The following is a description of a gene set: species: Homo sapiens Any process that modulates the frequency, rate or extent of any cellular process that depends upon or alters the microtubule cytoskeleton. Human Gene Set: GOBP_REGULATION_OF_MICROTUBULE_BASED_PROCESS, and this is the list of marker genes: APC, POC1A, CFAP43, CAMSAP3, NME7, MAP10, MAP6, EPPIN, BICD2, RBM14, TOGARAM1, SLC39A12, ODAD2, TPX2, CFAP206, BORCS5, MAPRE1, CAMSAP2, CFAP20, HAUS2, STMND1, AKAP9, CAMSAP1, CHMP6, ERBB2, ATXN7, FSD1, XRCC3, MID1, CDKN1B, DYNLT2B, STMN3, PHLDB1, HAUS3, GPSM2, MAPK15, RSPH4A, PKD1, ANKRD53, MAPT, DEFB1, CEP70, MAP6D1, SIRT1, SKA1, MCPH1, RAB6C, DRG1, CYLD, GAS2L1, PLK1, APC2, GSK3B, BBS2, PHLDB2, TAC1, POC1B, FNTB, MAP9 (NCBI Gene Id 79884), HAUS1, TMEM67, TPR, CLXN, IGBP1, PPP1R35, DCTN1, CENATAC, RNASE10, ATAT1, CYB5D1, CHMP1A, SENP6 (NCBI Gene Id 26054), FES, DNAAF1, CCDC65, CDK11B, FAM107A, CCDC39, TACC3, TTC21B, CLTC, RHOA, RPS3, CDK2AP2, HAUS7, CHMP3, WDR47, MAP1A, PPP2CA, NEFH, PGAM4, GEN1, BRCA1, MAP2, XPO1, BBS1, CDH5, SLAIN1, TEX101, PPP2CB, HDGFL3, CCSAP, MKKS, FKBP4, SASS6 (SAS-6 centriolar assembly protein), CHMP4A, DRC1, MARK2, RNF4, TACR3, CLIP1, CENPJ, RAC1, FBXW5, INPP5J, CEP131, CKAP2, NUP62, CLIP3, CHMP4C, TAC3, SEMG1, PDCD6IP, PLK4, BBOF1 (NCBI Gene Id 80127), FGF13, PSRC1, STMN1, SKA3, EML2, KLHL42, NAT10, MARK4, BICD1, ADAM7, HAUS4, ARHGEF7, HAUS8, KIF21A, IQCF1, PAK1, PRDM14, RCC1, TRAF3IP1, TACR2, CEP120, DIAPH3, VPS4B, GIT1, CHMP7, ROCK1, EFNA5, CDK5R1, PRKAA2, SNCA, HDAC6, ABL1, DIAPH1, CCNL2, SPEF1, BBS4, NAV3, CHORDC1, RUFY4, RUFY3, KIF18A, TRIM46, TRIM58, PAFAH1B1, ROCK2, CCNF, STMN4, TAC4, EPHA3, GNAI1, RIPOR2, DYNC1H1, ARHGEF2 (Rho/Rac guanine nucleotide exchange factor 2), CCR6, SKA2, EML3, STIL, RAE1, SPAST, BORA, MAP1S, ARL2, LAMP1, CAV3, TRPV4, CATSPER1, KAT2B (NCBI Gene Id 8850), CHMP5, CKAP5, CCNL1, CHMP2B, DYRK1A, CHMP4B (NCBI Gene Id 60501), CDK11A, BMERB1, CEP97 (NCBI Gene Id 79598), AURKB, FEZ1, PRUNE1, PRKAA1, MECP2, TTLL6, CEP295, TBCD, MET, GSK3A, HSPA1B, CCDC40, CHMP4BP1, GBA2, PKHD1, NPM1, TUBB4A, HAP1, PDE4DIP, CEP295NL, CHMP1B, SPAG5, WNT3A, MAPRE2, MAP1B, CFAP298, IRGC, TACR1, CLASP2, CHMP2A, PARP3, GAS2L2, KATNB1, OCLN, CIB1, SLAIN2, HAUS5, NUBP1, DIXDC1, HSPA1A, CLASP1, NUMA1, DNAH11, TRIM36, STK11, MID1IP1, MDM1, CCDC15, MAPRE3 (NCBI Gene Id 22924), C10orf90, SPECC1L, KIF9, MACF1, HNRNPU, TPPP2, SEMG2, HAUS6, STMN2, TRIM37, KAT2A, TRIM54, TAOK1, CCDC88C, FNTA, CFAP45, CEP76, PLK2, WDR62, ALMS1, TTBK2, AURKA, CFAP69, SPICE1, MEMO1, ATF5, TPPP, CDK5RAP2